The following is a description of a gene set: POU5F1 (OCT4), SOX2, NANOG activate genes related to proliferation Human Gene Set: REACTOME_POU5F1_OCT4_SOX2_NANOG_ACTIVATE_GENES_RELATED_TO_PROLIFERATION studied in species Homo sapiens, and this is the list of marker genes: NANOG, ZIC3, EPHA1, FGF2, CRIPTO, SALL4, STAT3, NR6A1, SOX2, SALL1, POU5F1, FOXD3, DPPA4